The following is a description of a gene set: studied in species Mus musculus Mouse Gene Set: MIR_468_5P Genes predicted to be targets of miRBase v22 microRNA mmu_miR_468_5p in miRDB v6.0 with MirTarget v4 prediction scores > 80 (high confidence targets). from publication Chen Y, Wang X (PMID 31504780), and this is the list of marker genes: Cdt1, Tfap2a, Smc6, Scml2, Hipk3, Psd3, Wapl, Gpm6a, Il1rap, Tcaim, Fut8, Klkb1, Zeb2, Nup107, Fmnl2, Cntn1, Ccser2, Sh2d7, Fut9, Steap2, Ppp2r5a, Mier3, Plcxd3, Clasp2, Gm5127, BC035044, Peg10, Ap3s1, Rspry1, Fbxo33, Uba6, Tsc22d2, Clec2e, Magee1, Pate5, Mtfr1, Zfp608, Rfx7, Chac2, Zfp148, Sec16b, Hspd1, Rasa2, Gm5458, Zfp217, Gm5916, Elavl4, Lin7a, Rhoj, Rapgef2, Pbx1, Riox1, Clasp1, Rnft1, Rnf24, Cep76, Kbtbd2 (kelch repeat and BTB (POZ) domain containing 2), Asap1, Myo9a, Tbc1d15 (NCBI Gene Id 66687)